Given this list of marker genes YIPF7, BET1, VTI1B (NCBI Gene Id 10490), YIPF5, YIPF4, VTI1A, USO1, here is a description of the gene set: The joining of the lipid bilayer membrane around a vesicle to the lipid bilayer membrane around the Golgi. species: Homo sapiens Human Gene Set: GOBP_VESICLE_FUSION_WITH_GOLGI_APPARATUS